The following is a description of a gene set: BACKGROUND: There are insufficient system-wide transcriptomic (or other) data that help explain the observed inter-individual variability in antibody titers after measles vaccination in otherwise healthy individuals. METHODS: We performed a transcriptome(mRNA-Seq)-profiling study after in vitro viral stimulation of PBMCs from 30 measles vaccine recipients, selected from a cohort of 764 schoolchildren, based on the highest and lowest antibody titers. We used regression and network biology modeling to define markers associated with neutralizing antibody response. RESULTS: We identified 39 differentially expressed genes that demonstrate significant differences between the high and low antibody responder groups (p-value <= 0.0002, q-value <= 0.092), including the top gene CD93 (p < 1.0E-13, q < 1.0E-09), encoding a receptor required for antigen-driven B-cell differentiation, maintenance of immunoglobulin production and preservation of plasma cells in the bone marrow. Network biology modeling highlighted plasma cell survival (CD93, IL6, CXCL12), chemokine/cytokine activity and cell-cell communication/adhesion/migration as biological processes associated with the observed differential response in the two responder groups. CONCLUSION: We identified genes and pathways that explain in part, and are associated with, neutralizing antibody titers after measles vaccination. This new knowledge could assist in the identification of biomarkers and predictive signatures of protective immunity that may be useful in the design of new vaccine candidates and in clinical studies. from publication Haralambieva IH, Zimmermann MT, Ovsyannikova IG, Grill DE, Oberg AL, Kennedy RB, Poland GA (PMID 27529750) Genes down-regulated in peripheral blood mononuclear cell vaccinated vs unvaccinated in adolescent/young adults (11-22) (high antibody responders to treatment) after exposure to M-M-R II, time point 7Y Human Gene Set: HARALAMBIEVA_PBMC_M_M_R_II_AGE_11_22YO_VACCINATED_VS_UNVACCINATED_HIGH_ANTIBODY_RESPONDERS_TO_TREATMENT_7YR_DN studied in species Homo sapiens, and this is the list of marker genes: CCL24, VEGFA, VNN1, FPR2, HTR7, CD33 (CD33 molecule), SGCD, CYP3A5, CD93, PID1